The following is a description of a gene set: studied in species Homo sapiens Human Gene Set: GOMF_UBIQUITIN_BINDING Binding to ubiquitin, a protein that when covalently bound to other cellular proteins marks them for proteolytic degradation., and this is the list of marker genes: NEDD4 (NCBI Gene Id 4734), RNF19B, JARID2, USPL1, TNFAIP3, NOD1, SPRTN, RNFT1, GGA3, TRIM32, CUEDC2, UBXN2A, SQSTM1, UEVLD, PLAA, UBXN2B, BIRC2, FAF1, CKS1B, WDR48, MARCHF7, FAF2, OTUB1, FAAP20, VPS36, SIRT2, HDAC6 (NCBI Gene Id 100820762), UBE2L6, CXCR4, STAM, RAD23B, UBE2N, KLF1, HSPB1, UBXN11, MAP3K7, FBXW7 (NCBI Gene Id 55294), CKS2, NUP62, NBR1, TAB2, SMAD3, HGS, TOM1L2, UBXN1, EPS15, FBXO7, AUP1, SHARPIN, VPS28, AMFR, USP25, DDI2, BUB3, MDM2, MARK4, SMARCAD1, UBXN8, NOD2, UBR5, TOP2A, UBE2A, RAE1, ZFAND2B, TOM1L1, RBCK1, CUEDC1, TAB3, UCHL1, STAM2, RNF168, OTUB2, NSFL1C, MVB12A, TP53INP2, TSG101, UBXN7, RNF31, DNAJB2, ASCC2, ILRUN, NPLOC4, TOLLIP, PRKN, OTULINL, DNAAF10, UBXN10, USP16, GGA1, RNF185, TOM1, GGA2, N4BP1, RNF8, USP33, N4BP2, MVB12B, USP13, UCHL3, IKBKG, USP5, UBAP1L, UBAP1, DHX16, RAD23A